The following is a description of a gene set: The stopping of bleeding (loss of body fluid) or the arrest of the circulation to an organ or part. Human Gene Set: GOBP_HEMOSTASIS species: Homo sapiens, and this is the list of marker genes: GP5, PF4, ACTB, COL3A1 (collagen type III alpha 1 chain), CD40LG, HPSE, PTPN6, ENTPD1, UBASH3B, ADGRG1, GNA13, DGKI, CD36, ALOX12, ANXA8, CLIC1, ADTRP, F13A1, TLN1, NOS3, ANGPT4, MFSD2B, F2R, THBS1, DTNBP1, STXBP1 (NCBI Gene Id 6812), GGCX, PPIA, DGKZ, AVPR2, FGB, AXL, KLKB1, ANXA2, SERPIND1, FUNDC2, IL6R, SHH, FZD6, TFPI, F2RL1, VAV1, SELP, BLOC1S3, TBXA2R, GNA12, PLSCR1, C1QTNF1, CAV1, PROZ (NCBI Gene Id 8858), VAV2, PIK3CB, FGG, FLI1, F5, DGKD, ANXA5, SLC4A1, CEACAM1, CTSG, CYP4F2, MMRN1, FCER1G, SERPINC1, MYH9, SRF, GNAS (GNAS complex locus), VAV3, HNF4A, GP6, WNT3A, TLR4, SVEP1, MYL9, COMP, ACTN1, ANGPT1, THBD, PLG (NCBI Gene Id 90749, plasminogen), DGKA, ANGPTL1, METAP1, PIK3CA, ILK (NCBI Gene Id 55522), JAK2, SERPINF2, TSPAN32, EPHB2, APOH, HRG, PTPRJ, FGL1, ADORA2A, ENTPD2, PDGFA, PABPC4, PLCG2, SERPINB2, PAFAH2, GPI, EDN1, SERPINE2, GP1BA, FIBP, DGKK, TFPI2 (tissue factor pathway inhibitor 2), LCK, C1GALT1C1, MPIG6B, ADRA2C, ITPK1, ANGPTL4, F12, F11R, SERPING1, CD9, PRDX2, PDGFB, PIK3CG, DGKB, FOXA2, GP1BB, GAS6, NFE2L2, USF1, LNPK, ADRA2B, ANGPT2, RAB27A (NCBI Gene Id 5873), FERMT3, PRSS56, ANO6, TSPAN9, CPB2, PRKG1, F2RL2, F9, HPS6, SLC6A4 (solute carrier family 6 member 4, NCBI Gene Id 6532), DGKE, GATA1, HBB, BLOC1S6, F13B, IL6ST, SERPINA1, PDPN, CELA2A, BLOC1S4, DGKQ, HGFAC (NCBI Gene Id 3083), PLEK (NCBI Gene Id 5341), ZNF385A, FBLN1, RAP2B, TUBB1, ITPR3, TREML1, PRKCQ, VCL, PRRG2 (proline rich and Gla domain 2), P2RY12, VKORC1, F8, PDGFRA, SLC7A11, FGA, VPS33B, ITGA2, F2RL3, JMJD1C, ITGB3, GNAQ, C4BPB, SYK, SERPINE1, SERPINA10, ADAMTS13, F11, TPH1, PEAR1, NFE2, F10, P2RY1, MYL12A, PROC, SAA1 (NCBI Gene Id 6288), ANGPTL7, PLAU, HPS4, TEC, TSPAN8, STXBP3, SCUBE1, PRRG4, DGKG, CD40, ADRA2A, RASA3, PDIA3, WAS, LMAN1, CYP4F11, F2, FAP, PROS1, FLNA, TSPAN18, MAPK14, SRC, KRT1, F3, ENPP4, DGKH, PRRG3, TYRO3, TMX1, PDIA2, AP3B1, PRKCA, EMILIN1, AK3, ANGPTL2, LYN, GP9, PLA2G4A, KNG1, SH2B3, PRKCD (NCBI Gene Id 5580), HPS5, IL6, ADAMTS18, HSPB1, ACTG1 (NCBI Gene Id 71), VWF, PROCR, EMILIN2, ANGPTL6, F7, PLAUR, MERTK, PLAT, VTN, APOE, CSRP1, HTR2A, CD59, ST3GAL4, PRRG1, P2RX1